The following is a description of a gene set: species: Mus musculus The chemical reactions and pathways involving monosaccharides, the simplest carbohydrates. They are polyhydric alcohols containing either an aldehyde or a keto group and between three to ten or more carbon atoms. They form the constitutional repeating units of oligo- and polysaccharides. Mouse Gene Set: GOBP_MONOSACCHARIDE_METABOLIC_PROCESS, and this is the list of marker genes: Ganc, Snord33, Pdx1, Pmm2, Kcnq1 (potassium voltage-gated channel, subfamily Q, member 1), Slc37a4, Pfkfb4, Ppp1r3g, Obp2a, C1qtnf3 (C1q and tumor necrosis factor related protein 3), C1qtnf1, Nudt5, Sirt1, Mup5, Dcxr, Mdh1, Irs2, Igfbp4, Gm1110, Mir423, Kcnj11, Gdf2, Pfkl, Pkm, Hkdc1, Prkaca, Prkaa1, Snord34, Pdk4, Supt20, Mup4 (major urinary protein 4), Fggy, Snord32a, Brat1, Glb1l2, Phkb, Ranbp2, Tpi1 (NCBI Gene Id 21991), Galk2, Ep300, Phkg1, Xpc, G6pc2, Gapdhrt2 (glyceraldehyde-3-phosphate dehydrogenase, retrotransposed 2), Chst1, Man2b2, Nfe2l1, Pdk3, Slc25a10, Gpld1, Ppp4r3a, Eno3, Tff3, Pik3ca, Fbp2, Nisch, Adipor1, Foxk2, Sord, Gmppb, Eno1b, Trp53, Ins1, Eno1, Acacb, Fbn1, Pgd, C1qtnf2, Oas1b, C1qtnf12 (C1q and tumor necrosis factor related 12), Apod, Gulo, Fuom, H6pd, B4galt1, Zfp692, Usf1, Slc45a3, Aldoc, Ugt1a6a, Ncoa2, Hk1, Hk3, Gale, Pth, Slc25a13, Pck1, Dyrk2, Adora2b, Fam3a, Mtcl2, Gapdhs, Akr1a1, Eno2, Acadm, Sds, Gsto1, Pfkp, Gcg, Lepr, Cpt1a, Aldh1a7, Gck, Esrrb, Foxk1, Uxs1, Galm, Phka1, Hif1a, Slc23a2, Mpi, Pdhb, Prkag1, Gpi1, Pck2, Glb1, Tfap2b (transcription factor AP-2 beta), Lipa (NCBI Gene Id 16889), Actn3, Gnb3, Akt2, Slc35b4, Gpd2, Fuca1, Khk, Oas1a, Pgk2, Sesn2, Kbtbd2, Epm2aip1, Ins2, Sirt6, Crtc2, Gclc (glutamate-cysteine ligase, catalytic subunit), Pfkfb1, Oas1e, Adra1b, Atf4, Il6, Igf1, Mst1, Nr3c1 (nuclear receptor subfamily 3, group C, member 1), Adcy10, Mup3, Gdpgp1, Bcl2l13, Pgm1, Oas1c, Arpp19, Kat2b, Igf2, Ogt, Erfe, Tnf, Pmm1, Rorc, Got1, Rbks, Fkrp, Oas1d, Bad, Lcmt1, Rbp4, Mdh2, Hmgb1, Fpgt, Pdha2, Chst15, Fuca2, Fabp5, Gpd1, Gnpda1, Galt, Tkfc, Ppp4r3b, Man2a2 (NCBI Gene Id 73354), Lrp5, Bckdk, Pgam2, Sorbs1 (NCBI Gene Id 75688), Oma1 (OMA1 zinc metallopeptidase), Bola3 (bolA family member 3), Foxo1, Src (NCBI Gene Id 99351), Per2, Aldob, Gnmt, Mapk14, Mup2, Man2a1, Errfi1, Hnf4a, Insr, Gpt, Glyctk, Slc25a12, Pgk1, Phkg2, Wdr5, Glb1l3, Igfbp3, G6pdx, Onecut1, Selenon, Lep, Tcf7l2, Kat2a, Serp1, Npy1r, Usp7, Ppara, Inppl1, Man1c1, Slc2a8, Zmpste24, Aldh1a1, Pfkfb2, Pmaip1, Pofut2, Fbp1, Mir143, G6pc3, Prkag3, Sik1, Myc, Gapdh, Oas1h (NCBI Gene Id 246729), Gpt2, Pgm2, Akr1b1, Slc39a14, Atp1a2, Nln, Gapdhrt, Clstn3, Car5a, Ppargc1a, Ldha, Man2c1, Prkag2, G6pd2, Rora, Wdtc1, Pdk1, Otog, Nkx1-1, B3glct, G6pc1, Hk2, Clk2, Adipoq, Mlycd, Ppp1r3b, Pgp, Stk11, Angptl8, Pfkm, Gsto2, Dlat, Adpgk, Ddb1, Glb1l, Dhdh, Dgkq, Aldoa, Cyp2j6, Mup11, Snord35a, Cbr2, Mup1, Pofut1, Tigar, Pik3r1, Fgl1, Dgat2, Ptpn2, Rpia, Hectd4, Ppp1r3e, Slc25a11, Xylb, Rgn, Pdk2, Pdha1, Oprm1, Pgam1, Otogl, Ero1a (endoplasmic reticulum oxidoreductase 1 alpha), Cry1, Pgm2l1, Pcx (NCBI Gene Id 18563), Atf3, Galk1, Oas1g, Ppp1ca, Atp1a3, Nnmt, Sirt7, Akt1, Oas1f, Man2b1, Irs1, Serpina12